The following is a description of a gene set: The commitment of cells to specific cell fates of the endoderm, ectoderm, or mesoderm as a part of gastrulation. Human Gene Set: GOBP_CELL_FATE_COMMITMENT_INVOLVED_IN_FORMATION_OF_PRIMARY_GERM_LAYER species: Homo sapiens, and this is the list of marker genes: PAF1, EYA2, SIX2, SMAD1, RTF1, FOXC2, KLF4, FZD7, FGFR1, TBX6, PAX2, SOX17, POU5F1, CDC73, DKK1, EYA1, LEO1, HNF1B, WNT3A, BMP4 (bone morphogenetic protein 4), SFRP2, BMPR1A, SOX2, TRIM15, CTR9, ETS2, GATA6 (GATA binding protein 6), CTNNB1, NANOG, NODAL, EOMES, HOXA11, ELF5, MESP1